Given this list of marker genes SNCA, NTNG1, DIP2A, LRFN5, HMCN2, L1CAM, ADGRF1, DVL1, PPFIA1, AMIGO2, AMOT, MESD, LRFN3, SLITRK3, BAIAP2, GABRB2, AGAP1, GABRA1, GSG1L, POU4F1, ZDHHC17, SPTBN4, SLC8A3, IGSF21, VPS35, IL1RAP, ERC2, GABRA6, FBXO45, CACNA2D2, PSEN1, KIF2C, GET1, CAST, CRKL, SNCB, SLC6A1, PLXNA3, C1QC, GIT1, PLXNA1, CDH8, DOCK10, ABI3, RAB39B, GABRA3, PFN1, EEF2K, GLRB, CTTNBP2, LINGO2, PCDHB11, LIN7C, CAPRIN1, DIXDC1, CASKIN1, LRRC4, OGT, AFG3L2, IGF1R, SNCG, C1QL3, NLGN4X, RIMS2, SRPX2, CYFIP1, PTEN, VLDLR, GPC4, SLC8A2, DLG5, RAB29, DCTN1, GNA13, SARM1, AMIGO3, SEMA4A, LNX1, NFIA, AMIGO1, LRP8 (LDL receptor related protein 8), GPRASP3, AGO2, DRD2, IL1RAPL2, THBS2, ITGA3, NCKIPSD, TANC2, ELFN1, PRRT1, INSR, SPOCK2, COL4A5, LAMB2, SNX27, NEDD4L, DOCK1, MRTFB, GABRA5, CRTAC1, NEDD9, PCDHB5, MUSK, RAB3A, IL1RAPL1 (NCBI Gene Id 4399), CBLN3, NTNG2, GABRA4, CTNND2, SNAPIN, LIN7A, GRM5, EFNA5, STAU1, DSCAM, C5AR1, PTPRF, PGRMC1, SIX1, RAC3, C1QA, CAMK2B, PTPN1, NEURL1, ADGRL2, LRFN1 (NCBI Gene Id 57622), LZTS3, STRN4, FGF22, CRMP1, LRRC24 (leucine rich repeat containing 24), PTK2B, RAC1, NF1 (neurofibromin 1), RPS6KA5, GNPAT, CDC20, GPM6A, PCDH8, WASF1, CRIPT, WASF3, ZDHHC15, SRCIN1, SEMA4C, SEZ6, CLN3, FRMPD4, SEZ6L2, NPAS4 (neuronal PAS domain protein 4), ADGRB3, EPHA4, F2R, ASIC2, RTN4R, SLC1A1, DNAJA3, SENP1, MEF2C, GABRA2, IGSF11, NTRK3 (neurotrophic receptor tyrosine kinase 3), NLGN4Y, HTR4, PDXP, CPNE6, FZD9, KY, SPTBN2, PDZD11, CDH2, DBNL, LRRN3, PRMT8, FGF7, SPG11, LINGO4, PPFIBP2, DAG1, PCLO, APPL1, DNM3, CDC42, EPHB1, GABRG3, VANGL2 (NCBI Gene Id 57216), FLRT2, ARF1, EZR, RELN, NEFL, CTTN, ARHGAP44, CTNNA2, CUX2, LHFPL4, LRRK2, PTPN13, ANK3, RHOB (ras homolog family member B), AKT1, GABRG2, SDK1, VCP, FILIP1, TPBG, KIRREL3, CYFIP2, DMPK, C1QL1, STK38, CHCHD10, DOK7, REST, ZNF365, ITGB1, WNT7A, PCDHGC3, VSIG10, TUBA1A, WASF2 (WASP family member 2), GABRB3, PLXND1, ARMCX5-GPRASP2, CDH9, PCDHB4, DRP2, DNER, NRXN1, CNTN4, DISC1, PLXNB2, NLGN1, LGMN (NCBI Gene Id 5641), FARP1, ABHD17A, SPARCL1, SEMA3E, NEGR1, LRRTM2, LRP4, FLRT1, FZD1, CFL1, ABI2, POTEI, ASIC1, LRRN1, CBLN4, ACTBL2, CHD4, RAP1B, ROCK1 (NCBI Gene Id 6093), GPR158, PTPRD, PCDHB2, LRFN4, CTNNB1, ANAPC2, ADD2 (adducin 2), POTEE, CDH6, CX3CL1, IL10, TNR (NCBI Gene Id 7143), RIMS3, PTPRS, CHRNA1, LARGE1, WNT7B, NECTIN1, SLITRK5 (NCBI Gene Id 26050), NEDD4, FLRT3, TNC, GJA10, PCDHB6, ZNF804A, RER1, PCDHB3, NLGN2, LRRC4B, APOE, ARC, CACNA1S, CHRNB1, GHSR, MAP1B, FRRS1L, IQSEC2, SIX4, LATS1, EPHA7, ARHGEF15, SEZ6L, CAMKV (NCBI Gene Id 79012), PCDHGC5, NUMBL, GAP43 (growth associated protein 43), ZDHHC12, ETV5, PICK1, CD2AP, PDZRN3, PCDHB16, TMEM108, ARHGAP33, CC2D1A, CHMP2B, PPFIA3, PRNP, BSN, WASL, ITGB3, BCAN, ENAH, NPTN, CX3CR1, LRTM2, SYNGAP1, CLASP2, NTN1, DOCK4 (dedicator of cytokinesis 4), SHISA6, NECTIN3, PPP1R9B, CAMK1, ST8SIA2, CNTNAP1, CACNB2, ARHGAP39, EIF4G1, NRP2, PCDHB9, SDF4, INSYN1, NGEF, RIMS1, CDK5 (NCBI Gene Id 1020), LRFN2, ADGRB1, OPHN1, PLXNB1, ACTL8, KIF5B, MYCBP2, ALS2, POTEF, FGFR1 (NCBI Gene Id 84151), GDNF, CDKL5, PLXNC1, POTEKP, NLGN3 (NCBI Gene Id 54413), LAMA5 (NCBI Gene Id 3911), DLGAP4, CACNB4, ARHGEF9, ACHE, LIN7B, CHRDL1 (NCBI Gene Id 91851), P2RX2, POTEJ, HOMER1, ADAM10, ADNP, CAP2, TNF, TENM4, SYNDIG1, ROBO2, PPFIBP1, LILRB2, DLG1 (discs large MAGUK scaffold protein 1), SLC18A3 (solute carrier family 18 member A3), PPFIA4, SLITRK2, SEMA3F, FYN, IGSF9, SLC30A1, SLITRK4, ABHD17B, PRKCA, MAPK14, PCDHGC4, GRM6, TLN2, NFATC4, ABHD17C, CAP1, SEMA4D, CLSTN3, PIN1, RHOA, ADGRB2, SRGAP2, MTMR2, TREM2, PLS3, ELFN2, MYOT, LRIT3, SEMA7A, ITSN1, TSC1, S1PR2 (NCBI Gene Id 9294, sphingosine-1-phosphate receptor 2), KLK8, KCNJ8, CACNA2D3, RHOG, SRGAP2C, ZC4H2, EPHB2, CNKSR2, PFN2, CRK, SYN1, GABRE, ZDHHC8, TLR2, APP, UBE2M (NCBI Gene Id 9040), IL10RA, INS, GRIA1, SHANK1, NAE1, PLXNB3, GPHN, CDK5R1, SYBU, SLIT1 (NCBI Gene Id 6585), ARHGAP12, NTRK2, DAB1, LRRTM3, CBLN2, CNTN2, PPFIA2, ELMO1, SHISA7, SLC12A5, PALM, DLG4, RAPSN, PAK3, CHRNB2, NRP1, FZD5, SSH1, MDGA1, HAPLN4, BDNF, GHRL, PAFAH1B1, ACTG1, RYK, ERBB4, OXT (oxytocin/neurophysin I prepropeptide), CLSTN1 (calsyntenin 1), MYH10, SDK2 (NCBI Gene Id 54549), FGF13, LRRTM1, PRICKLE1, C3, SHANK2, FNTA, HIP1R, EFNA1, NEFH, EFNB2, ZDHHC2, DAB2IP, PTPRO, NTRK1 (NCBI Gene Id 7825), STAU2, ERBB2, ZMYND8, DTNBP1, TUBB, DAAM1, CNTN5, SLC25A46, PCDHB14, UBE3B, DHX36, CACNG2, CHRNA7, NRG3, APBB2, COLQ, YWHAZ, PLXNA4, ACTB, FCGR2B, PCDH17, SYN2, ITGAM, SLITRK1, SORT1, MECP2 (methyl-CpG binding protein 2), INA, PDLIM5, C1QB, MIR30B, DLGAP3, NOS1AP, COL4A1, RAB17, ICAM5, ARF6, NRN1, SETD5, PLXNA2, PLPPR4, HDAC6, CNTN6, ACTN1, PUM2, TRIM47, ADGRL3, GRIN2B, GRID1, LRRC4C, PCDHB10, ARHGAP22, CDH1, EGLN1, CSMD2, RTN4, WNT3A, NRXN2, EPHB3, DRD1, NEUROD2, RAP2A, SLITRK6, LMX1A, GABRG1, SIGMAR1, AGRN, KIF1A, NEDD8, VSTM5, CAPRIN2, CCDC39, NPTX1, LGI2, SIPA1L1, GRN, PTK7, SLC7A11, ERC1 (NCBI Gene Id 84770), SYN3, NRCAM, SPARC, DKK1, MARK1, CARMIL3, ACTN2, SPTB, LZTS1, ITPKA, ABL1, CDH10 (cadherin 10), SH3GL2, MAPT, KCNK13, CBLN1, SRGAP2B, TANC1, SHANK3, C1QL2, WNT5A, MIR431, GRID2, DBN1, CLSTN2, ARF4, PCDHB13, here is a description of the gene set: A process that is carried out at the cellular level which results in the assembly, arrangement of constituent parts, or disassembly of a synapse, the junction between a neuron and a target (neuron, muscle, or secretory cell). Human Gene Set: GOBP_SYNAPSE_ORGANIZATION studied in species Homo sapiens